The following is a description of a gene set: species: Mus musculus Genes positively differentially expressed in cell type: Treg upon treatment with cytokine: IL-2 in mouse lymph nodes in vivo. Mouse Gene Set: CUI_TREG_IL2_RESPONSE_UP Cytokines mediate cell-cell communication in the immune system and represent important therapeutic targets. A myriad of studies have highlighted their central role in immune function, yet we lack a global view of the cellular responses of each immune cell type to each cytokine. To address this gap, the authors created the Immune Dictionary, a compendium of single-cell transcriptomic profiles of more than 17 immune cell types in response to each of 86 cytokines (>1,400 cytokine-cell type combinations) in mouse lymph nodes in vivo. A cytokine-centric view of the dictionary revealed that most cytokines induce highly cell-type-specific responses. For example, the inflammatory cytokine interleukin-1β induces distinct gene programmes in almost every cell type. A cell-type-centric view of the dictionary identified more than 66 cytokine-driven cellular polarization states across immune cell types, including previously uncharacterized states such as an interleukin-18-induced polyfunctional natural killer cell state. from publication Cui A, Huang T, Li S, Ma A, Pérez JL, Sander C, Keskin DB, Wu CJ, Fraenkel E, Hacohen N (PMID 38057668), and this is the list of marker genes: Sdad1, Rbm25, Pcbp1, Rtp4, Mrpl19, Il4ra, Capn2, Uqcc2, Mrpl30, Lap3, Pfn1, Pno1, Rexo2, Septin9, Tnfrsf18, Prpf31, Pmepa1, Uhmk1, Nherf1, Atp1a1, Fam162a, Ndufaf4, Shmt2, Acsl5, Phgdh, Rrp1b, Agpat3, Pdia6, Srsf6, Pa2g4, Hnrnpu, Ptpa, Atic, Aimp2, Rer1, Csrnp1, Ccnd2, Capg, Twf1, Ssb, Myl6, Ppia, Cacybp, Kif3b, Noc4l, Rpn2, Ifi47, Tnfrsf4, Eif3a, Castor1, Aatf, Gbp4, Gbp7, Tap2, Bop1, Eif5a, Prmt1, Zdhhc20, Gbp5, Cs, Lta, Tsr1, Cd48, Psma7, Sco2, Atp5mc1, Ncoa3, Eif4a1 (eukaryotic translation initiation factor 4A1), Npm1, Gpatch4, Uchl3, Epcam, Coro1a, Ndufa4, Isg20l2, Eif4g1, Apex1, Banf1, Mettl1, Anp32b, Kars1, Polr1a, Fubp1, Hnrnpab, Gpr83, Il10ra, B2m, Prdx4, Dnaja2, Tapbpl, Cisd3, Cish, Mllt6, Hnrnpa2b1, Il2ra, Socs2, Ezh2, Hspe1 (NCBI Gene Id 15528), Wnk1, Cltc, Vasp, Pole4, Adam19, Pdia4, Tuba1b, Pfkp, Tnfsf10, Ppp1r14b, Cox6a1, Nacc1, Flt3l, Mybbp1a, Cndp2, Ddx21, Coro2a, Tuba4a, Mrfap1, Tmem147, Iigp1, Psmb10, Lyz2, Fabp5, Nap1l1, Tars1, Mrps28, Kti12, Itih5, Pum3, Cdca7, Ltv1, Ddx17, Sema4d, Ndufaf8, Syncrip, Eno1, Gnl3, Rpn1, Lcp1, Snu13, Irf1, Foxp3, Papolg, Osm (NCBI Gene Id 18413), Stat1, Noc2l, Dennd5a, Cdk6, Rrp15, Psmb8, Hsp90b1 (heat shock protein 90, beta (Grp94), member 1), Mrpl23, Cmtm6, Dnajc2, Ppa1, Rnf19b, Lsm7, Ebp, Emc4, Irgm2, Set, Larp1b, Anp32e, Irgm1, Ccdc88b, Hsp90ab1, Med29, Utp18, Nabp1, Gbp6, Psme2, Gmppb, Mat2a, Gbp3, Lsm6, Cad, Socs1, Wsb1, Txn2, H2-T23, Psma6, Dtx3l, Phc3, Usp10, Xbp1, Cyb561d2 (NCBI Gene Id 56368), Nup210, Wdr18, Aida, Erh, Clint1, Nhp2, Kpna1, Dicer1, Timm50, Mif, Aldh18a1, Mrps34, Sacs, Larp4, Ltb, Brd2, Eif4g2, Cct2, Stat3, Ptma, Calhm6 (NCBI Gene Id 215900), Mrpl17, Serpina3g, Glrx3, Zbp1, Spg7, Hspd1, Mapkapk3 (NCBI Gene Id 235596), Pebp1, Mia2, Nsun2, Dph5, Zdhhc8, Gtf3a, Sfxn1, Chchd1, Sem1, Trim21, Samhd1, Bpnt2, Izumo1r, Psmb9, Ccdc86, Psmb4, Myb, Lrpprc, Snrpf, Rnf213, Rrs1, Calr, Bzw1, Icos, Eftud2, Ldha, Fasn, Srm, Hsp90aa1, Tomm40, Tap1, Prdx1, Serbp1, Timm13, Canx (calnexin), Wars1, Cct8, Wdr82 (NCBI Gene Id 77305), Calm1, Lrrc32, Psma2, Tubb4b, Cyth1, Mrto4, Ube2j2, Vim, Snx10, Npm3, C1qbp, Rrp1, Vars1, Mrpl12, Casp8, Ranbp1, Tbca, Nop58 (NCBI Gene Id 55989), Isg20, Rbm3, Nop16, Trip12, Il2rb, G3bp1, Parp14, Igtp, Atad3a, Txn1 (NCBI Gene Id 22166), Psat1, Gbp2, Psmb5, Med8 (mediator complex subunit 8), P2ry10, Psmd7, Cyba, Gart, Eif4a3, Bst2, Gcsh, Actg1, Ube2l6, Cfl1, Atp5f1d, Hspa9, Atp5f1b, Lsm4, Actl6a, Cox5a, Cct7, Cd53, Akap13, Ptges3, Kpnb1, Slc14a1 (NCBI Gene Id 72142), Mbd2, Ftsj3, H2az1, Nlrc5 (NLR family, CARD domain containing 5), Timm8a1, Celsr1, Ncl, Larp1, Gar1, Psme1, Rbm15b, Zfp593 (NCBI Gene Id 68040), Prmt3, Ran, Nme1, Rragd (NCBI Gene Id 70641), Cd2, Ywhae, Aen, Cycs, Galk1, Itga6, Tgfb1, Hspa5, Parp9, Bcl3, Timm10, Eprs1, Pkm, Pim1, Srsf2, Rars1, Isg15, St6galnac4, Hspa8, Fbl, Phb1, Akt2, Sypl1, Pml, Wdr46, Rcc2, Nip7, Htt, Rap1gds1